Given this list of marker genes CCDC124, FOXN3-AS1, CCL8 (C-C motif chemokine ligand 8), S100A6, COQ4, UTS2, CYP4F8, BYSL, EMD (NCBI Gene Id 2010), MYH15, S100A12, GRIP2 (NCBI Gene Id 80852), HIF3A, UBTF, NUDT12, UCK1, DYRK2, ALPK2, KRTAP5-2, MT2A, MRGPRX1, FAM216B, DYDC1, SRD5A3, CRELD2, CRNDE, C12orf43, CCDC38, OR5H1, FDX2, MAGEE2, R3HCC1, PITPNA, CRISP2, FIBP, KCNH2, DMRT3, CST6, AASS, PAQR5, KIF1A, FLRT1, DMRTB1, VWA1, PM20D1, MARCHF1, CSKMT, PRG2, BRMS1, DESI1, PPIB, B3GNT5, SLC35C1, ELMOD1, SLAMF7, ZNF208, PBX2, FAM118B, ACAD9, USP49, CLUH, CHGB, TTC9B (NCBI Gene Id 148014), ZSWIM1, TMEM39B, PLEKHA7, ZFPL1, ARHGEF10, EPC2, MT1HL1, SPTBN4, SLC25A44, CXCL10, GAGE1, CHST2, MKX, THAP7-AS1, SLC41A2, SPRING1, MUC7, C3orf36, DDX49, LRRC8C, IQSEC1, ACBD6, TLE2, MTNR1B, PIK3R2, TMEM145, TMEM237, IDO1, MT1X, NINJ1, PPAN (peter pan homolog), C9, ABCG2, HBE1, FBXW8, C3orf52, KRT10-AS1, PRSS16, PRRG2, PGAP3, TRNP1, CCL22, LIN7A (NCBI Gene Id 8825), SEPTIN1, KBTBD11, GPC3, CST11, GTSF1L, TAFAZZIN, RAPGEFL1, ENSG00000258422, HEATR1, INMT, CHODL (chondrolectin), SEMA4B, KXD1, LINC00485, SEPTIN10, FCGR2B, DHRS7C, CD70, IER3, SPON2, SLC52A1, PRDM13, RRS1, ADH7, C14orf178 (NCBI Gene Id 283579), ZNF471, SLC25A5-AS1, DPPA3, ZNF875, ASRGL1, TUBB2B, RECQL5, CMAS, TRMT61A, IGSF9B, CNTNAP4, ENTPD7, KLF10, STUB1, SPAG6, CD80, BASP1, ERMAP, TIMD4, PAEP, PRSS53, ATP2C2, CSF2RA, SPRYD3, SLC39A3, C19orf25, RAB31, PIP5KL1, DNAJC9, SAPCD2, STUM, PPARD, ABHD17C, HSPA1A, FRG2EP, MT1H, KCNE2, TOM1, SLC12A9, HDGF, GPATCH3, ARHGEF26-AS1, C1QTNF4, ZNF585B, TDO2, KRTAP8-1, TREML2, PGAP6, RAPGEF4, LTA, NOVA1, PSORS1C1, PRMT1, KRT8, CRH, ALG3, AHRR, CTSS, TMEM143, MTG1, MT1E, TRDMT1, CCSER2, here is a description of the gene set: Human CD14 positive monocytes were purified from healthy volunteers’ blood and cultured in vitro for 4, 12, 24, 72 hours. While culturing, macrophages were activated alternatively with interleukin-4 (IL-4 100 ng/ml) or classically with interferon-gamma (IFNg 100 ng/ml)+tumor necrosis factor (TNF 50 ng/ml) or left without activation. Simultaneously, macrophages were also treated with vehicle (DMSO:ethanol) or 1mM synthetic PPARg agonist, Rosiglitazone. We used Affymetrix microarrays (U133Plus 2.0) to analyze activation and PPARg-induced gene expression changes. Genes down-regulated in macrophages (12h): control versus rosiglitazone. from publication Szanto A, Balint BL, Nagy ZS, Barta E, Dezso B, Pap A, Szeles L, Poliska S, Oros M, Evans RM, Barak Y, Schwabe J, Nagy L (PMID 21093321) Human Gene Set: GSE16385_UNTREATED_VS_12H_ROSIGLITAZONE_TREATED_MACROPHAGE_DN studied in species Homo sapiens